Given this list of marker genes Eaf2, Wdr43, Vhl, Polr2m, Eaf1, Tefm, Cdk9, here is a description of the gene set: Mouse Gene Set: GOMF_TRANSCRIPTION_ELONGATION_FACTOR_ACTIVITY A molecular function that stimulates the elongation properties of the RNA polymerase during the elongation phase of transcription. A subclass of transcription elongation factors enable the transition from transcription initiation to elongation, while another class rescue stalled RNA polymerases. species: Mus musculus